Given this list of marker genes BMP5, BMP2, CILP, OVOL2, CSNK2B, MAP1LC3A, UCMA, VEPH1, GLCE, GDF5, TBX20, GDF15, DKK1, PPARG (peroxisome proliferator activated receptor gamma), PML, GREM1, LDLRAD4, TGFBR2, ATOH8, MIR146A, FOS, LRP1, TWSG1, CRKL, MIR26B, BECN1, HFE, DAB2, EMILIN1, SMAD9, JAK2, NODAL, TOB1, BMPR2, MIR27A, INHBA, NOG, GDF6, MIR195, BMP7, HIPK2, ZMIZ2, PARP1, SMAD3, MAGI2, MIR145, ACVR2A, CCN3, NUP93, SMAD5, JUN, SH2B1, MIR199A1, MIR483, SMAD4, BMPR1A, ENG, MIR23A, FAM89B, MIR140, TGFB3, BMP4, PIN1, RBPMS, SMAD2, TGFB1, SPTBN1, GDF11, TGFBR3 (NCBI Gene Id 7049), BMP10, MIR26A1, WWTR1, TGFBR1, XBP1, SMAD6, MIR323A, GDF7, SMAD1, TGFB2 (transforming growth factor beta 2), KIAA0319, SKI, ZMIZ1, TTK, MIRLET7G, ACVRL1, AMH, PMEPA1, MIR885, RUNX2, MIR101-1, BMP6, ACVR1, MIR130A, MIR204, SMAD7, CITED1, EID2, BMPER, GDF2 (growth differentiation factor 2), PSG9, PIAS2, MIR205, here is a description of the gene set: studied in species Homo sapiens An intracellular signaling cassette that starts with the activation of a SMAD protein, leading to the formation of a complex with co-SMADs, which translocates to the nucleus and regulates transcription of specific target genes. Human Gene Set: GOBP_SMAD_PROTEIN_SIGNAL_TRANSDUCTION